The following is a description of a gene set: Reduced amount of the thyroid-stimulating hormone (TSH), which is produced by the anterior pituitary gland and stimulates the function of the thyroid gland. Human Gene Set: HP_DECREASED_THYROID_STIMULATING_HORMONE_LEVEL Decreased thyroid-stimulating hormone level studied in species Homo sapiens, and this is the list of marker genes: ROBO1, HESX1, LHX4, MANF, LHX3, POU1F1, TSHR (NCBI Gene Id 7253), TSHB, CPE, PROP1, OTX2, KCNJ18, THRB